The following is a description of a gene set: studied in species Mus musculus Human Gene Set: KAMMINGA_EZH2_TARGETS from publication Kamminga LM, Bystrykh LV, de Boer A, Houwer S, Douma J, Weersing E, Dontje B, de Haan G (PMID 16293602) Putative targets or partners of EZH2 in hematopoietic stem cells. The molecular mechanism responsible for a decline of stem cell functioning after replicative stress remains unknown. We used mouse embryonic fibroblasts (MEFs) and hematopoietic stem cells (HSCs) to identify genes involved in the process of cellular aging. In proliferating and senescent MEFs one of the most differentially expressed transcripts was Enhancer of zeste homolog 2 (Ezh2), a Polycomb group protein (PcG) involved in histone methylation and deacetylation. Retroviral overexpression of Ezh2 in MEFs resulted in bypassing of the senescence program. More importantly, whereas normal HSCs were rapidly exhausted after serial transplantations, overexpression of Ezh2 completely conserved long-term repopulating potential. Animals that were reconstituted with 3 times serially transplanted control bone marrow cells all died due to hematopoietic failure. In contrast, similarly transplanted Ezh2-overexpressing stem cells restored stem cell quality to normal levels. In a genetic genomics screen, we identified novel putative Ezh2 target or partner stem cell genes that are associated with chromatin modification. Our data suggest that stabilization of the chromatin structure preserves HSC potential after replicative stress., and this is the list of marker genes: SETDB1, NEK2, SMC4, DNTT, TOP2A, NUSAP1, DBF4, PPP1CC, NAP1L1, H2AZ1, PRIM1 (NCBI Gene Id 5557), TACC3, AHCY, CCNB2, PCNA, TOPBP1, GMNN, MCM3, EED, MKI67, MCM2 (NCBI Gene Id 94687), MAD2L1, KPNA2, CUL2, XPO1, POLE2 (DNA polymerase epsilon 2, accessory subunit), RRM1, TFDP1, CDCA7, IPO5, HAT1, RBL1, RFC1, MCM4, ECT2, CDCA5, SMC2 (NCBI Gene Id 10592), RPA3, AURKB, AURKA, PRC1